The following is a description of a gene set: Mouse Gene Set: GOBP_L_AMINO_ACID_TRANSPORT studied in species Mus musculus The directed movement of L-enantiomer amino acids into, out of or within a cell, or between cells, by means of some agent such as a transporter or pore., and this is the list of marker genes: Dtnbp1, Slc38a5, Slc17a6, Slc7a8, Slc7a11, Slc43a1, Slc11a1, Slc43a2, Slc6a15, Gnat2, Slc7a9, Slc6a20a, Slc38a6, Slc36a2, Slc1a6, Slc25a13, Slc66a1, Slc47a1, Arl6ip5, Slc25a18, Rab3gap1, Arg2, Sfxn3, Kcnj8, Slc17a7, Arg1, Slc17a8, Pak1, Epm2a, Ttyh1, Kcnj10, Ntsr1, Slc1a3, Slc25a29, Slc25a2, Slc25a22, Slc1a5, Slc7a6, Slc7a2, Arhgef11, Cln3, Stxbp1, Cln8, Ttyh2, Slc7a7, Septin2, Slc3a2, Slc25a15, Slc16a10, Ucp2, Slc38a4, Nat3 (N-acetyltransferase 3), Abcc8, Slc6a17, Slc36a4, Slc25a26, Grik1, Grm1 (glutamate receptor, metabotropic 1), Arl6ip1 (NCBI Gene Id 97394), Nf1, Sfxn1, Tnf, Ace2, Slc1a4, Ctns, Slc15a4, Vps54, Slc38a1, Slc1a2, Llgl2, Slc22a2, Slc36a1, Cltrn, Kmo, Slc38a2, Slc3a1, Ttyh3, Slc6a20b, Slc1a7, Itgb1 (integrin beta 1 (fibronectin receptor beta)), Psen1, Slc7a3, Per2, Slc38a3, Slc1a1, Slc7a5, Slc7a13, Agt, Slc7a1, Slc38a9, Slc36a3, Slc25a12